The following is a description of a gene set: Mouse Gene Set: REACTOME_PLASMA_LIPOPROTEIN_REMODELING species: Mus musculus Plasma lipoprotein remodeling, and this is the list of marker genes: Mttp, Lmf1, Apoe, Apoc2l, Lipg, Angptl4, Pcsk5, Apoa2, Apoa1, Gpihbp1, Lcat, Apob, Lpl, Angptl8, Lipc, Abcg1, Angptl3, Apoa4, Lmf2, Apoc2, Alb, Apoa5, Furin, Pltp, Pcsk6, P4hb